The following is a description of a gene set: species: Mus musculus Mouse Gene Set: GOBP_ENDOTHELIUM_DEVELOPMENT The process whose specific outcome is the progression of an endothelium over time, from its formation to the mature structure. Endothelium refers to the layer of cells lining blood vessels, lymphatics, the heart, and serous cavities, and is derived from bone marrow or mesoderm. Corneal endothelium is a special case, derived from neural crest cells., and this is the list of marker genes: Adamts12, Ptprs, Pdgfb, Afdn, Atoh8, Dsg2, Zeb1, Fasn, Rdx, Bmpr2, Hey2, Tgfbr1, Abcb1b, Tnf, Col18a1, Proc, Naglu, Rhoa, Gja1, Gja4 (gap junction protein, alpha 4), F2rl1, S1pr2, Krit1, Mir874, Fzd1, Ctnnb1, Dll4, Dicer1, Acvrl1, Itgax (integrin alpha X), Marveld2, Cysltr1, Notch4, Slc40a1, Rap2c, Foxc2, Tie1, Prox1, Sox17, Vcl, Pdpn, Lipa, Cldn1, Gdf2, Tnmd, Xdh, Notch1, Cd2ap, Rapgef1, Hpse, S1pr3, Apold1, Ren1, Flvcr2, Barx1, Tjp1, Ceacam1, Ubiad1, Cldn5, Robo4, Zdhhc21, Vhl, Gpx1, Tjp3, Bsg, Plod3, Smad4, Bmpr1a, Add1, Rap1b, Pdcd10, Vezf1, Ezr, Pde4d, Sox18, Hey1, Ppp1r16b, Etv2, Cxcr4, Rapgef2, Bmp6, Vegfa, Rapgef3, Mesp1, Rock2, Rap1a, Plcb1, Magi1, Heg1, Hapln2, Nrg1, Fzd4, Pbrm1, Jag1, Bloc1s6, F11r, Acvr1, Cnmd, Hoxb5 (homeobox B5), Ednrb, Rbpj, Rhob (ras homolog family member B), Il1b, Agt, Btg1, Cd34, Tmem100, Edn1, Msn, Amotl2, Stc1, Id1, Ccm2, Akap11, Arhgef26, Myadm, Pde2a, Ndp, Lcn2, Fzd2, Clic4, Cul7, Foxp1, Acvr2b, Abcc1, Stard13, Kdr, Cldn3, Cxcl10, Prok2, Foxp3, Ednra, Rock1, Pecam1, Ift88, Nr2f2, Kdm6b, Foxj2, Met, Hoxa13, S1pr1, Tjp2, Fgf1, Dmd, Fstl1, Myd88, Bmp4, Csnk2b, Ikbkb, Icam1, Dll1 (delta like canonical Notch ligand 1), Cdh5, Alox12, Tnfrsf1a